The following is a description of a gene set: Human Gene Set: GOBP_SUBPALLIUM_DEVELOPMENT species: Homo sapiens The process whose specific outcome is the progression of the subpallium over time, from its formation to the mature structure. The subpallium is the base region of the telencephalon., and this is the list of marker genes: CNTNAP2, LRRK2, GSX2, INHBA, SECISBP2, DLX2, DRD1, BBS4, FOXP1, SLC7A11, ZSWIM6, FGF8, GLI3, SHANK3, OGDH, FOXP2, DLX1, ALDH1A3, ASCL1, RARB, DRD2, BBS1 (Bardet-Biedl syndrome 1), BBS2, HPRT1, SLITRK5, MKKS, BCL11B